The following is a description of a gene set: A process that is carried out at the cellular level which results in the assembly, arrangement of constituent parts, or disassembly of structures formed of microtubules and associated proteins in the cell cortex, i.e. just beneath the plasma membrane of a cell. Human Gene Set: GOBP_CORTICAL_MICROTUBULE_ORGANIZATION species: Homo sapiens, and this is the list of marker genes: KANK1, DLG1, TLN1, PPFIBP1, KIF21A, PPFIA1, EZR, TRPV4, PAFAH1B1